Given this list of marker genes MR1, DDX23, APLNR, THBS3, RAG1 (NCBI Gene Id 5896), ANKRD1, ADAMTS8, HOXC4, COL9A2, SCNN1A, RIN1, RGS1 (regulator of G protein signaling 1), PRICKLE1, TAMALIN, COL4A2, KLHDC9, GPATCH2, MMP14, BLOC1S1, ARHGAP30, KRT74, TPM1, CBL, SLC2A3, RDH5, RNF220, PYM1, ANK3, SCN8A, FOXN3, PDZRN4, PXN, MDGA2, PTPN7, TMCO1, CARMIL3, RILPL1, PLEKHA6, IFNG (interferon gamma), ASCL4, LRP5, NRXN3, NFRKB, JMJD1C, CNIH3, MRPS31, C1orf198, STRC, DNM3, CADM1, ENTPD1, SWT1, GPR137B, KIF1B, NRAS, HHIPL1, SNX1, RHOG, UBL3, NOTCH2, DKK1, ITGB7, HP1BP3, AKAP3, MIR17HG, FRMD4A, HLX, DGKA, CD69, SLC37A2, NGB, S100A9, MYOD1, HIPK1, GRHL3 (NCBI Gene Id 57822), NAV3, SH3BP5L, SLC12A6, NSUN4, NOTCH2NLA, C11orf42, PDE3B, PRRG4 (proline rich and Gla domain 4), EIF3J, RABGAP1L, TCF12, ACSL5, CORO1C, SLITRK5, RASGEF1A, XCL1 (X-C motif chemokine ligand 1), EDARADD, CD101, RNF19B, CELF1, CTSK, RAB39A, NR4A1, BGLAP, DNHD1, CALCOCO1, ZBTB18, EIF2B3, PLXNC1, NDUFA9, ARHGAP32, FOXD2, CHRNA10, SRSF4, MSMB, SLC6A9, LRMDA (NCBI Gene Id 83938), LMO2, BMF, NHLRC2, ZBTB8A, PGF, AP1G2, C14orf119, FLI1 (NCBI Gene Id 2313), SCEL, DACT1, OTOGL, GRK5, PTPN22, HINFP, TSPAN32, SLC15A3, FGD4, SOX5, IL23A, TBK1, VRK1, TMEM117, RCOR2, NKX2-1, ADAMTS4, ATN1, EMSY (EMSY transcriptional repressor, BRCA2 interacting), PRR5L, SLC37A4, CSTPP1, PIGV, VSIG10, CD6, BICDL1, FCER1G, MRPL42, ATF7IP, SPRYD3, DYNLL1, BLOC1S2, ANXA8, RCC2, TMEM151A, TNFSF4, RAB30, CRTAC1, ACIN1, PDZK1, TACC2, LMO3, GPD1, TLL2, TACSTD2, MOAP1, FAM13C, MTX1, ID3, TSPAN9, RGS18, LY9, BATF3, LUZP1, NUCB2, PSMA1, ARHGAP42, JDP2, TNNT2, STAT2, TLCD5, CYP17A1, MMP13, INTS3, AGO1, TRMT1L, LCK, HOATZ, RASAL2, FGF4, RAB5B, MATN1, BTG4, MAP3K11, EMP1, INPPL1, KCTD4, PHF21A, PAX6, DAB1, XCL2 (NCBI Gene Id 82261), ZBTB25, CKMT1B, CALHM3, MEIS2, EGR2, AP5B1, DNAJC14, CREM, SGIP1, POU2F1, TMEM109, DNASE2B, SCN3B, PCF11, TMEM86A, HDGF, DIABLO, SYT9, SPATA17, TBX5, CLDN10, ATP6V0B (ATPase H+ transporting V0 subunit b), ITGA10, TMEM62, KCNJ1, REXO2, MKRN3, CRTC2, ABCD4, ARNT, MADD, RORC, DENND2D, MPL, ARHGEF2, SEMA4A, ATP2A2, GZMB, CRY1, HSP90B1, ARHGAP21, ARHGAP12, MIA2, PICALM, COL4A1, MTMR11, GPBP1L1, MSRB3, SCN2B, ARF3, LCOR, SMG7, BATF (NCBI Gene Id 10538), CAP1, GTF2A1, KRT73, VIM, SIRT1, HIVEP3, BCAR3, PACS1, SUPT16H, CCDC91, WNT8B, PDE6H, HOXC6, TWF1, PCGF6, SELENOH, LINC02694, here is a description of the gene set: species: Homo sapiens Genes having at least one occurrence of the motif TGTGGT in the regions spanning 4 kb centered on their transcription starting sites. This matches the RUNX1 transcription factor binding site V$AML1_Q6 (v7.4 TRANSFAC). Human Gene Set: AML1_Q6